Given this list of marker genes Ndufs5, Acsl1, Dnajc8, Col3a1, Adrb3, Ghr, Mmp3, Adig, Chchd10, Zfp703, Ccl11, Dgat1, Mfng, Npc2, Col1a1, Mmut, Sowahc, Cd34, Srpx, Tmem43, Clec3b, Sorbs1, Krt19, Plac8, Qki, Lpin1, Atp1b3, Jchain, Ephx2, Fcgbp, Gyg1, Phldb1, Bnip2, Idh1, Net1, Col5a1, Derl1, Dhrs7, Tmem205, St3gal6, Col18a1, Pdha1, Cdc34b, Fam107b, Pgm1, Rab34, H6pd, Acta2 (actin alpha 2, smooth muscle, aorta), Thbd, Fads1, S100a6, Igfbp6, Marcks, Sqor, Dpt, Plpp1, Slc27a1 (NCBI Gene Id 26457), Ugt1a2, Cd151, Aldh1a7, Mknk2, Fez2, Mocs2, Ccdc80, Tsc22d1, Gpd2 (NCBI Gene Id 99372), Rragc, Snrk, Mrc1, Uqcr10, Lamb1, Gjb2, H2-Aa, Map4, Gas6, Cyp4b1, Myl9, Fzd4, Ces1d, Scp2, Ndufv1, Papss2, Gstz1, Man1a, Gpam, Sult1a1, Ivd, Klf4, Gja1, Cavin3, Pde8a, Lum, Cidec, Aplp2, Hadh, Gpx3, Ptprb, Rspo1, Acaa1a, Fstl1, Bckdhb, Tgfbi, Penk, Lyl1, Hadhb, Cd36, Dpep1, Ppp2r5a, AW112010, Decr1, Idh2, Ptges, Abhd5, Eif4ebp1, Gbe1 (1,4-alpha-glucan branching enzyme 1), Vwf, Chpt1, Cyb5a, Etfb, Mccc1, Cpt2, Ly6a, Cxcl12, Adipor2, Auh, Cyb5b, Nrp1, Alas1, Hspb8, Sptbn1, Ndufab1, Acaa2, Nr1h3, Col6a3, Angptl2, Cfp, Htra1, Alad, Postn, Bcat2, Cavin2, Ywhag, Sec23a, Phyh (NCBI Gene Id 98889), Ahnak, Nkiras1, Crip1, Col4a1, Gnai1, Zeb1, Gdpd3, Heph, Uck1, here is a description of the gene set: from publication Landis MD, Seachrist DD, Montañez-Wiscovich ME, Danielpour D, Keri RA (PMID 15897883) Mouse Gene Set: LANDIS_ERBB2_BREAST_TUMORS_324_DN Upregulation of HER2/ErbB2/Neu occurs in 15-30% of human breast cancers and correlates with poor prognosis. Identification of ErbB2/Neu transcriptional targets should facilitate development of novel therapeutic approaches. Development of breast cancer is a multistep process; thus, to identify the transcriptomes associated with different stages of progression of tumorigenesis, we compared expression profiles of mammary tumors and preneoplastic mammary tissue from MMTV-Neu transgenic mice to expression profiles of wild-type mammary glands using Affymetrix microarrays. We identified 324 candidate genes that were unique to ErbB2/Neu-induced tumors relative to normal mammary gland tissue from wild-type controls. Expression of a subset of these genes (82) was also changed in the preneoplastic mammary glands compared to wild-type controls, indicating that they may play a pivotal role during early events of ErbB2/Neu-initiated mammary tumorigenesis. Further analysis of the microarray data revealed that expression of several known transforming growth factor (TGF)-beta target genes was altered, suggesting that the TGF-beta signaling cascade is downregulated in ErbB2/Neu-induced tumors. Western blot analysis for TGF-beta-Receptor-I/ALK5 and immunohistochemistry for TGF-beta-Receptor-I/ALK5 and phosphorylated/activated Smad2 confirmed that the Smad-dependent TGF-beta signaling cascade was inactive in these tumors. Although absent in most of the tumor, phosphorylated Smad2 was present in the periphery of tumors. Interestingly, presence of phosphorylated/activated Smad2 correlated with expression of Activin-Receptor-IB/ALK4, suggesting that although Smad-dependent TGF-beta signaling is absent in ErbB2/Neu-induced tumors, Activin signaling may be active at the leading edge of these tumors. Cumulatively, these data indicate that the TGF-beta pathway is intrinsically suppressed in ErbB2/Neu tumors via a mechanism involving loss of TGF-beta-Receptor-I/ALK5. Down-regulated genes from the genes identified by two analytical methods as changed in the mammary tumors induced by transgenic expression of ERBB2. studied in species Mus musculus